The following is a description of a gene set: A high expression level of the beta-actin protein is required for important biological mechanisms, such as maintaining cell shape, growth, and motility. Although the elevated cellular level of the beta-actin protein is directly linked to the long half-life of its mRNA, the molecular mechanisms responsible for this effect are unknown. Here we show that the RNA-binding protein HuR stabilizes the beta-actin mRNA by associating with a uridine-rich element within its 3' untranslated region. Using RNA interference to knock down the expression of HuR in HeLa cells, we demonstrate that HuR plays an important role in the stabilization but not in the nuclear/cytoplasmic distribution of the beta-actin mRNA. HuR depletion in HeLa cells alters key beta-actin-based cytoskeleton functions, such as cell adhesion, migration, and invasion, and these defects correlate with a loss of the actin stress fiber network. Together our data establish that the posttranscriptional event involving HuR-mediated beta-actin mRNA stabilization could be a part of the regulatory mechanisms responsible for maintaining cell integrity, which is a prerequisite for avoiding transformation and tumor formation. Genes down-regulated in HeLa cells upon knockdown of ELAVL1 by RNAi. from publication Dormoy-Raclet V, Ménard I, Clair E, Kurban G, Mazroui R, Di Marco S, von Roretz C, Pause A, Gallouzi IE (PMID 17548472) Human Gene Set: DORMOY_ELAVL1_TARGETS species: Homo sapiens, and this is the list of marker genes: MYT1, PDCD1LG2, ACTB, CDC7, CDKN3, CCNA2 (NCBI Gene Id 890), SPAG9, EDNRA, RBM8A, PIDD1, BAAT, CCND3 (NCBI Gene Id 896), PDCD10, ATXN2, CNNM2, BAG2, CDK2, IL6